Given this list of marker genes SLC31A2, IFT88, VARS1, ZEB1, RYBP, PPP1R2, INSL4, SLC39A6, HACD3, ALDH6A1, FBXW2, PIP4K2B, BCL2A1, S100P (S100 calcium binding protein P), PHLDA1, TOMM34, PABPC4, ACSL1 (acyl-CoA synthetase long chain family member 1), SPECC1L, MRPL19, SLC26A2, CAPZA1, AKT2, UROS, RFXAP, TAF10, NUP88, ABI2, TSN, KIT, TRIP6, TWF1, CANX, CCNA2, MLIP, LIMD1, here is a description of the gene set: Genes up-regulated in response to hydorgen peroxyde in CS-B cells (Cockaine syndrome fibroblast, CS) with defficient ERCC6. species: Homo sapiens Human Gene Set: KYNG_RESPONSE_TO_H2O2_VIA_ERCC6_UP from publication Kyng KJ, May A, Brosh RM Jr, Cheng WH, Chen C, Becker KG, Bohr VA (PMID 12606941) Cockayne syndrome (CS) is a human hereditary disease belonging to the group of segmental progerias, and the clinical phenotype is characterized by postnatal growth failure, neurological dysfunction, cachetic dwarfism, photosensitivity, sensorineural hearing loss, and retinal degradation. CS-B cells are defective in transcription-coupled DNA repair, base excision repair, transcription, and chromatin structural organization. Using array analysis, we have examined the expression profile in CS complementation group B (CS-B) fibroblasts after exposure to oxidative stress (H2O2) before and after complete complementation with the CSB gene. The following isogenic cell lines were compared: CS-B cells (CS-B null), CS-B cells complemented with wild-type CSB (CS-B wt), and a stably transformed cell line with a point mutation in the ATPase domain of CSB (CS-B ATPase mutant). In the wt rescued cells, we detected significant induction (two-fold) of genes out of the 6912 analysed. The patterns suggested an induction or upregulation of genes involved in several DNA metabolic processes including DNA repair, transcription, and signal transduction. In both CS-B mutant cell lines, we found a general deficiency in transcription after oxidative stress, suggesting that the CSB protein influenced the regulation of transcription of certain genes. Of the genes, 122 were differentially regulated by more than two-fold. Evidently, the ATPase function of CSB is biologically important as the deficiencies seen in the ATPase mutant cells are very similar to those observed in the CS-B-null cells. Some major defects are in the transcription of genes involved in DNA repair, signal transduction, and ribosomal functions.